The following is a description of a gene set: Binding to a molecule and eliciting a change in the protein's activity in response to the intracellular level of that molecule. species: Mus musculus Mouse Gene Set: GOMF_MOLECULAR_SENSOR_ACTIVITY, and this is the list of marker genes: Rad51b, Syt15, Msh5, Micu2, Pkd2l1, Ica1, Micu1, Micu3, Rad51, Castor1, Rad51d, Msh2, Mlh1, Zfp598, Nlrp3, Efhd1, Gmppa, Egln2, Pick1, Nme2, Syt4, Syt12, Syt9, Syt17, Park7, Trpa1, Xrcc3, Xpc, Syt2, Syt5, Scn7a, Tmem63a, Dmc1 (NCBI Gene Id 13404), Pms2, Syt13, Sar1a, Rad51c, Msh6, Tmem63c, Map3k20, Sar1b, Xrcc2, Rad23b, Syt8, Sirt6, Syt1, Gck, Arfip2, Syt6, Gckr, Syt11, Efhb, Msh3, Ndufs2, Efcab9, Slc38a9, Syt7, Tmem63b, Trpv4, Slc39a4, Gcn1, Syt3, Msh4, Pelo, Syt10